Given this list of marker genes KCTD1, NDNF (neuron derived neurotrophic factor), TP63, GNRHR, DCC, FSHR, DUSP6, GMNN, GLI2, IKBKG, TWIST2, FGF17, REV3L, GNRH1, WDR11, BNC1, TBX3, TACR3, CHD7, SEMA3A, LHX4, ORC1, CCDC141, BMP15, ZSWIM7, MAF (MAF bZIP transcription factor), YY1, FSHB, FGFR1, DYRK1A, NIN, PROK2, PROP1, CDC6, NUP107, ESR1, ORC6, POU1F1, USP9X, PSMC3IP, CDT1, ANTXR1, ANOS1, OTX2, MRPS22, FOXA2, EFNB1, TAC3, SOX3, SOX10, PLXND1, NSMF, HESX1, CDC45, LMNA, ORC4, POC1A, PROKR2, KISS1, IL17RD, NR5A1, SPRY4, FEZF1 (FEZ family zinc finger 1), NHLH2 (nescient helix-loop-helix 2), FLRT3, MSH4, ACTB, FGF8, HS6ST1, POLR3H, SPIDR, KISS1R, here is a description of the gene set: Absence or underdevelopment of the breasts. Human Gene Set: HP_APLASIA_HYPOPLASIA_OF_THE_BREASTS Aplasia/Hypoplasia of the breasts species: Homo sapiens